Given this list of marker genes SLC25A16, B4GALT5, INHA, TPST1, UPK1B (uroplakin 1B), KCNA1, THBS2, SYT17, B4GAT1, TCTA, FAM50A, FILIP1L, ETV5, GPRASP1, CD27, NRG1, GRB14, MYLK, TNFSF12, NKX2-1 (NK2 homeobox 1), TSPAN1, CFH, MYO10, TRO, B4GALT4, COL11A1, C22orf31, PEG10, PCK1, FZD1, SLC6A1, EML1, RDH11, GALR3, RNASE4, PLCB1, HBEGF, KHDRBS3, ITGA6, CRMP1, AKAP12, NRP1, NAT2, DPYSL3, KDM5D, NT5E, MARCO, FOLR2, LGMN, TNC, ING1, NAP1L3, CD3D, FGF7, PLXNB1, ALOX5, LOXL1, PDGFRL, FKBP1B, IL1RAP, LTB, JCHAIN, ELOVL6, MDK, MX1, PDYN, NOVA2, BCAR3, ARL4D, MMP13, CBY1, P4HA2 (prolyl 4-hydroxylase subunit alpha 2), KCNB1, TOB2, PIAS3, FETUB, SERPINI1, GNG11, IL9, SLC22A1, CLEC4M, BAIAP3, GZMK, SLC16A4, CNR2, ZNF365, PTPRE, GRIN1, IGF2, BCKDK (NCBI Gene Id 94996), KCNS1, EPHA7, COG5, TXN2, TRIM9, DOP1B, INHBB, BBOX1, PRSS12, NPY, SCRG1, ARHGEF4, SYNE2, PAPSS2, IGF1, ALDH7A1 (aldehyde dehydrogenase 7 family member A1), RGS13, HRAS, CRYGA, IFIT3, MYH8, EFNA1, LEPR, SCHIP1, TMEM8B, PCDH9, ID4, PCCA, SEMG1, KCNK2, GATB, AMY2B, GPC4, IFI44L, FGFR1, RAC3, H2BC11, WASF3, SMTN, TSPAN7, CDKN2A, DPAGT1, VLDLR, GRK5, CCL17, CGA, PRR4, BCL2L1, FZD7, ARHGDIG, CYP2B6, GULP1, GAS8, C14orf132, TULP2, MGST3, CD247, SSPN, SPP1, PTPRM (protein tyrosine phosphatase receptor type M), CEACAM6, EFEMP1, LPIN2, ADH1B, LDOC1, ZNF593, SETBP1, DLX5, SFRP1, ARSB, SMAD3, TUSC3, SLC10A1 (solute carrier family 10 member 1), MAPK8IP2, SERPINF2, ZNF821, ME3, LILRB5, LAMA3, ARHGEF10, MTSS1, BCL9, ATP1A2, SLC7A8, RALGPS1, ZP3, CASK, FOXO4, ST3GAL1, HPX, ABLIM1, CHRNB2, OAS1, SFTPC, RFX2, APOC1, CD52, DBN1, ETFB, CELSR1, PDE2A, KIR3DL1, RGL1, PSPHP1, GPKOW, MRC1, TPM2, KMT2A, BCHE, BMP2, TCFL5, GAS1, HDAC9, GZMA, CEACAM1, NOL4, PSPH, AFP, PROM1, RNASE1, GPRC5B, CRHBP, DNAJB2, UGT2B10, FADS3, UNC13B, CYB5R1, CTNNA2, GADD45G, here is a description of the gene set: Human Gene Set: MODULE_129 species: Homo sapiens Signaling.